The following is a description of a gene set: Genes containing one or more binding sites for (MSX1) in their promoter regions (TSS -1000,+100 bp) as identified by GTRD version 20.06 ChIP-seq harmonization. studied in species Homo sapiens Human Gene Set: MSX1_TARGET_GENES from publication Yevshin I, Sharipov R, Kolmykov S, Kondrakhin Y, Kolpakov F (PMID 30445619), and this is the list of marker genes: KIAA1217, DNAJB4, ITGB6, SKA3, YWHAZ, SLC38A6, TANK, RPL17, WSB2, OGDH, GIRGL, CETN3, PSME2P3, TMEM18, ATP5PB, RPS11, USP54, COQ2 (coenzyme Q2, polyprenyltransferase), SRI, MANCR, EGF (epidermal growth factor), MACC1, DBR1, YIPF3, RNU5E-1, SLC30A10, ZFC3H1, QKI, TSPAN12, TPR, STRIP1, COG5, NAA38, FKBP7, PDSS2, HCG14, SMARCAD1-DT, KATNB1, RPS9, IL20RA, SMC4, SERPINB5, ATF7-NPFF, COX11, IQCG, RPL4, GEMIN2, TARDBP, SMG5, IFT80, MDH2, KLF5, METTL16, RNU6-952P, PSMD5, BCLAF1, SNORD1C, YOD1, ANXA2R-AS1, NXPE2, H3C9P, POLR3A, ZNF704, HMGXB3, DUS4L, SEPTIN7-DT, FAM200B, AGPS, MPC2, MBP, CDK12, HUWE1, CYB5D1, RBM39, MPZL3, ENTPD4-DT, TTC21B, STXBP4, MPPE1, FUBP1, HSPD1, SETD5, POLR1C, NCOA4, PPP2CA, CREBZF (NCBI Gene Id 58487), LINC02038, BCAS3, PNN (NCBI Gene Id 5411), SMARCAD1, COQ5, ERCC6L2-AS1, NXPE1, ENC1, DUT, ZZZ3, RPL35A, PRR5L, SUN1, STYXL1, CLDN12, RAMAC, RPS6, GIPC2, DCTN2, CEP120, VMP1, HMGN2P46, PPCDC, ZRANB3, AFF4-DT (NCBI Gene Id 124901065), TMEM209, BTG3-AS1, MEGF11, EFCAB14, R3HDM1, CLPB, TMEM79, CEP350, SRP19, ERGIC2, HNMT, DENR, TOM1L2, LINC02363, RBM26, FAM47E, SNORD58B, ZWILCH, ERCC6L2, ARID5B, XPNPEP1, RBM15, HOMER2, ANKFY1, RPL21, DRAIC, GAPDHP25, DLD, SLC17A1, SLC7A11, TUBGCP5, THAP2, WDR77, C6orf89, RC3H2 (NCBI Gene Id 54542), GCA, ERAP1, FBXL5, OSGEPL1-AS1, YAE1, DNMBP, SCYL3, MEF2C, RNF43, SMNDC1, IMP3, ATF7, ENTPD4, NLN, MAPK14, TDP2, ZNF317, FAM135A, CDC5L, HMG20A, INO80, MRPL57, OSGEPL1, DST, HMGCR, PEAK1, CCDC124, LEKR1, CFAP70, GLRX, RPL17-C18orf32, C1orf226, SLC39A9, PFKFB2, ENSG00000249295, MRPS14, SRSF10, ANKS4B, TLR3, DRC3, USO1, IFIH1, RNU1-134P, SNHG16, SEPTIN7, TMOD3, SKAP2, LTBP1, ITGB5, PFN2, MAP3K7 (mitogen-activated protein kinase kinase kinase 7), CCDC192, HOXA-AS3, ERH, BCL2L14, DCAF6